Given this list of marker genes Rplp2, Aars1, Smyd5, Cpeb3, Cpeb2, Nemf (nuclear export mediator factor), here is a description of the gene set: The successive addition of amino acid residues to a nascent polypeptide chain during protein biosynthesis in the cytoplasm. studied in species Mus musculus Mouse Gene Set: GOBP_CYTOPLASMIC_TRANSLATIONAL_ELONGATION